Given this list of marker genes GJA1, CCNQ, SMARCA4, TRAF7, MCTP2, NOTCH1, LRPPRC, GNB2, SMAD2, DAW1, MMP21, NKX2-5, ZIC3, PLXND1, here is a description of the gene set: A congenital defect with failure to open of the mitral valve orifice. studied in species Homo sapiens Human Gene Set: HP_MITRAL_ATRESIA Mitral atresia